The following is a description of a gene set: Mouse Gene Set: GOBP_NEGATIVE_REGULATION_OF_B_CELL_APOPTOTIC_PROCESS species: Mus musculus Any process that stops, prevents, or reduces the frequency, rate, or extent of B cell apoptotic process., and this is the list of marker genes: Aurkb, Mir19b-1, Foxp1, Mir92-1, Mir19b-2, Mif, Mir106b, Bcl2a1a, Il2, Mir20b, Mir363, Irs2, Mir92-2, Mir18b, Mir93, Il3, Bcl10, Mir25, Bcl2, Cd44, Noc2l, Slc39a10, Hsh2d, Cd74, Ada, Ormdl3, Pdcd1, Mir106a